Given this list of marker genes Idi1, Sc5d (sterol-C5-desaturase), Msmo1, Idi2l, Hmgcs1, Lss, Nsdhl, Mvk, Hmgcr, Ggps1, Pmvk, Ebp, Mvd, Sqle, Cyp51, Dhcr24, Acat2, Hsd17b7, Idi2, Tm7sf2, Srebf1, Arv1, Srebf2, Fdft1, Plpp6, Dhcr7, Lbr, Fdps, here is a description of the gene set: Cholesterol biosynthesis Mouse Gene Set: REACTOME_CHOLESTEROL_BIOSYNTHESIS studied in species Mus musculus